The following is a description of a gene set: part of: p75 NTR receptor-mediated signalling Reactome Pathway: Cell death signalling via NRAGE, NRIF and NADE This event has been computationally inferred from an event that has been demonstrated in another species.<p>The inference is based on the homology mapping from PANTHER. Briefly, reactions for which all involved PhysicalEntities (in input, output and catalyst) have a mapped orthologue/paralogue (for complexes at least 75% of components must have a mapping) are inferred to the other species. electronically inferred by orthology from the curated human pathway studied in species Mus musculus, and this is the list of marker genes: Ywhae, Arhgef15, Casp3, Arhgef12, Fgd2, Ngf, Bad, Casp2, Gna13, Arhgef39, Itsn1, Sqstm1, Arhgef17, Arhgef7, Psenen, Arhgef10l, Arhgef38, Itgb3bp (NCBI Gene Id 67733), Prex1, Ubb, Mapk8, Rps27a, Psen1, Arhgef3, Arhgef37, Ngef (neuronal guanine nucleotide exchange factor, NCBI Gene Id 53972), Fgd1, Arhgef1, Arhgef10, Arhgef33, Ngfr, Vav1, Sos2